The following is a description of a gene set: Human Gene Set: GOBP_MENAQUINONE_CATABOLIC_PROCESS species: Homo sapiens The chemical reactions and pathways resulting in the breakdown of menaquinones, any of the quinone-derived compounds synthesized by intestinal bacteria. Structurally, menaquinones consist of a methylated naphthoquinone ring structure and side chains composed of a variable number of unsaturated isoprenoid residues. Menaquinones have vitamin K activity and are known as vitamin K2., and this is the list of marker genes: CYP4F12, CYP4F3, CYP4F11, CYP4F8, CYP4F2